The following is a description of a gene set: species: Mus musculus Mouse Gene Set: GOBP_CHONDROCYTE_DEVELOPMENT_INVOLVED_IN_ENDOCHONDRAL_BONE_MORPHOGENESIS The progression of a chondrocyte over time from after its commitment to its mature state where the chondrocyte will contribute to the shaping of an endochondral bone., and this is the list of marker genes: Tgfbr2, Poc1a, Rarg, Serpinh1, Matn1, Sox9 (NCBI Gene Id 70015), Smpd3 (sphingomyelin phosphodiesterase 3, neutral), Col27a1, Cst5